The following is a description of a gene set: Mouse Gene Set: GOMF_FOUR_WAY_JUNCTION_DNA_BINDING Binding to a DNA segment containing four-way junctions, also known as Holliday junctions, a structure where two DNA double strands are held together by reciprocal exchange of two of the four strands, one strand each from the two original helices. species: Mus musculus, and this is the list of marker genes: Hmgb3, Hmgb1, Mecp2, Gen1, Xrcc3, Hmg20b, Msh2, Men1, Yy1, Xrcc2, Blm, Rad51d, Msh6, Wrn, Rad51b (NCBI Gene Id 19363), Abl1, Fancm, Rad51c